The following is a description of a gene set: species: Mus musculus Genes predicted to be targets of miRBase v22 microRNA mmu_miR_12205_5p in miRDB v6.0 with MirTarget v4 prediction scores > 80 (high confidence targets). from publication Chen Y, Wang X (PMID 31504780) Mouse Gene Set: MIR_12205_5P, and this is the list of marker genes: Zfp874a, Meis2, Ywhae (NCBI Gene Id 22627), Klf6, Klri2, Samd7, Galnt13, Crk, Creg2, Tsc22d2, Adamtsl3, Pura, Ric8b, Zbtb34, Kcnv1, Trim2, Jarid2, Tmprss11g, Sema3a, Usp15 (NCBI Gene Id 70921), Osbp, Slco6d1, Scml4, Nos1, Tenm4, Rgs4, Fyco1, Pros1, Rsbn1, Inpp5a, Cadm4, Egfr, Khdc1b, Nfib, Tfpi2, Cldn1, Lrrtm1, Il18r1, Ggnbp2, Slc12a1, Pkia, Bnc2 (NCBI Gene Id 71498), Rock2, Foxk1, Pramel22, Fos, P3h3, Fubp3, Nfkbid, Elavl4, Cyria, Tnik, Tmem164, Galnt16, Slc16a2, Klf9, Tmod1, Zfp738, Magi2, Tbata, Gpatch2l, Pex5l, Car3, Zfp781b, Zfp827, Zscan18, Lats2, Lrrc2, Zfp704, Camsap2, Plagl2, Sema6a (NCBI Gene Id 353045), Hnf4g, Cpox, Cdr2l, Satb1, Cert1, Wnk2, Adam22, Rora, Kcne4, Map2, Hgf, Lrrc32, Tnf, Pcmtd2, Insr, Adamts18, Nedd4, Bud13, Fam199x, Clta, Reep6, Ppard, Ube2e3, Tiparp, Adamts5, Ppfibp2, Erbb4, Peg10, Pum2 (pumilio RNA-binding family member 2), Pex14, Arl4c, Krit1 (KRIT1, ankyrin repeat containing), Gm14322, Dipk2b, Dll1 (delta like canonical Notch ligand 1), Mfsd11, Cdh12, Ctdp1, Rras2, Echdc1, Mavs, Shprh, Iqub, G3bp2, Slc2a13, Fam163a, Mier1, Cldn34c1, Zfhx2, Tmprss11a, Slc12a6 (NCBI Gene Id 93718), Jpt2, Taf3 (TATA-box binding protein associated factor 3), Defb12, Prkab2, Nos1ap, Gad1, Shroom2, Bltp1, Gabrb1, M6pr, Ywhag, Ttll7, Slc8a1, Stx5a, Gstm3, Ube2k, Jam2, Chmp7, Zfp386, Ncapg2, Zeb2, Gm15881, Tfdp1, Atp6v0a1, Arid1a, Cyp2j5, Acap2, Rbm48, Nalf1, Pou2f1, Ergic2 (NCBI Gene Id 67743), Rps6, Tgif2, Mybl1, Slc39a2, Pde1a, Rbms1, Mtor, Ddx4, Ankrd54, Heyl, Pou3f4 (POU domain, class 3, transcription factor 4), Cd86, Ppm1l, Adgre4, Shoc2, Nagk, Ttc27, Fam210b, Hs1bp3, Sema5a, Mrap2, Cyp2c50, Caprin1, Map4k5, Tbl1xr1, Nkd1, Nkapd1, Esr1, Scn1a, Smarca2, Mtpn, Fbxo33, Gabrb3, Nlgn3, Zfp810, Csnk1g3, Zfp119a, Tab2